The following is a description of a gene set: Glutamate and glutamine metabolism species: Homo sapiens Human Gene Set: REACTOME_GLUTAMATE_AND_GLUTAMINE_METABOLISM, and this is the list of marker genes: GLUD1, ALDH18A1, RIMKLB, GOT2, PYCR2, GLS2, RIMKLA, GLS, GLUL, PYCR3, PYCR1, KYAT1, OAT, GLUD2